The following is a description of a gene set: Reactome Pathway: Factors involved in megakaryocyte development and platelet production part of: Hemostasis electronically inferred by orthology from the curated human pathway studied in species Mus musculus This event has been computationally inferred from an event that has been demonstrated in another species.<p>The inference is based on the homology mapping from PANTHER. Briefly, reactions for which all involved PhysicalEntities (in input, output and catalyst) have a mapped orthologue/paralogue (for complexes at least 75% of components must have a mapping) are inferred to the other species., and this is the list of marker genes: Tuba3b, Tubal3, Kif1b, Kifap3, Racgap1, Kif5b, H3c11, Prkaca, H3c2, H3c1, Gata4, Kif20a, Tuba8, Gata2, Rbsn, H3c4, Cdc42, Kif2b, Kif27 (NCBI Gene Id 75050), Kif21a, H3c3, Tubb4a, Klc4, H3c15, Kif26a, Dock2, Ak3, Kif9 (kinesin family member 9), Tubb4b, Kif12, Kif2c, Tuba1c, Zfpm1, Tuba1b, Itpk1, Ehd2, Nfe2, Ehd3, H3c13 (H3 clustered histone 13), Gata6, Prkar1b, H3c10, Mfn2, Cenpe, Tuba1a, Mafk, Tuba4a, Ehd1, Dock5, Tubb6, Gata3, Maff, Rad51c, H3c8, H3c7, Prkar2b, H3f3a, Rad51b, Kdm1a, Sh2b3, H3c6, Kif18b, Gata1, Klc3, Kif3c, Tubb2b, Prkacb, Dock8, Dock11